The following is a description of a gene set: from publication Abbas AR, Baldwin D, Ma Y, Ouyang W, Gurney A, Martin F, Fong S, van Lookeren Campagne M, Godowski P, Williams PM, Chan AC, Clark HF (PMID 15789058) studied in species Homo sapiens Human Gene Set: GSE22886_DAY0_VS_DAY1_MONOCYTE_IN_CULTURE_DN Genes down-regulated in comparison of monocytes cultured for 0 days versus those cultured for 1 day. Immune cell-specific expression is one indication of the importance of a gene's role in the immune response. In order to identify such patterns, we set out to broadly profile gene expression in a variety of immune cells., and this is the list of marker genes: GNA15, TALDO1, IL6, PXDC1, RFTN1, GP5, H2BC12, UGCG, SLC7A5, ADAMDEC1, SDC4, BCAP31, MMP19, GARS1, TRAPPC4, TUBB6, NME7, TP53BP1, ALCAM, RALA, GADD45G, CCL4, ZNF557, PSMD11, BCAT1, PSMC4, MANF, RGL1, ZFYVE16, BASP1, BIRC3, TNIP2, YIPF6, ATOX1, KCTD7, MMP9, RDX, CLEC5A, PIP4K2C, MICALL1, IER3, FICD, PSMB5, MAFG, FADS3, KYNU, UPP1, FEN1, TEX10, RHOF, UNC13B, CAMSAP2, STAC, SOWAHC, MAPK6, ORMDL2, CLN8, MT1H, CXCL2, ST3GAL1, ZNF267, LMNA (lamin A/C), MGLL (monoglyceride lipase), GPX4, AARS1 (alanyl-tRNA synthetase 1), CLN5, SH3GL1, NRIP3, TSC22D1, C3, LAPTM4B, ETS2, SPP1, SEC61G, TRIP10, ACSL5, RUNX1, ARL8B, CTSB, CD63, CTSL, TXN, SLC2A3, PTGS2 (prostaglandin-endoperoxide synthase 2), SH3BP5, FCMR, DUSP4, CD2BP2, TRAF1, SPINK1, GPR137B, TXNRD1, ZHX2, INHBA, CDKN1A, TUBB, PPIF, WNT5A, TNFRSF4, EBI3, PSMC1, CCL22, ABCC1, NPC1, SOD2, IL3RA, ARL1, NFKBIE, ATP1B3, LAMP3, TUBG1, GSDME, CTSV, MYO1E (myosin IE), PPP1R14B, KEAP1, ATP6V1D, RRAGC, ANKLE2, PIM1, NQO1, IL1B, PPBP, MAPK13 (NCBI Gene Id 5603), PFKFB3, PI4K2A, PSMB2, PIM2, TNFRSF1B, IL1RN (interleukin 1 receptor antagonist), SLAMF7, VDR, IL7R, PPME1, PDE4A (phosphodiesterase 4A), TUBB4B, PHACTR1, SERPINB2, CXCL1, MTF1, STAT4, SLCO4A1, FTH1P5, TNFSF14, CCNA1, ZBTB43, GMPPB, GSTO1, NINJ1, GLRX2, CCL2, SLC7A11, EMP1, RAB13, MAFF, VPS37C, MRC1, CCR7, KCNN4, ZBTB17, AK4, PJA1, PLA2G7, MT1X, CCRL2, PI3, TTI2, DAB2, CRIM1, STX4, WTAP, ATP13A3, PSMA6, HIVEP2, ZC3H12A, AGPAT4 (1-acylglycerol-3-phosphate O-acyltransferase 4), GM2A, TXNL1, CYP1B1, TMEM208, RHOQ, CREB3, PLIN2, PSMD14, CXCL3, ATP6V1H, SLC3A2, CRLF2, HBEGF, NAMPT, CSTB, TNIP1, H2BC12L, SLC43A3, FTH1, MITF, SPHK1, MT2A, TNFAIP6, DOCK4